The following is a description of a gene set: studied in species Homo sapiens The Lysophospholipid receptor (LPLR) group are members of the G protein-coupled receptor family of integral membrane proteins that are important for lipid signaling. In humans there are eight LPL receptors, each encoded by a separate gene (these genes also sometimes referred to as "Edg" or endothelial differentiation gene). The ligands for LPLRs are the lysophospholipid extracellular signaling molecules, lysophosphatidic acid (LPA) and sphingosine 1-phosphate (S1P). The primary effects are inhibition of adenylyl cyclase and release of calcium from the endoplasmic reticulum, as well as secondary effects of preventing apoptosis and increasing cell proliferation (Contos JJ et al, 2000; An S et al, 1998; Fukushima N and Chun J, 2001). Reactome Pathway: Lysosphingolipid and LPA receptors part of: Class A/1 (Rhodopsin-like receptors), and this is the list of marker genes: S1PR3, S1PR1, PLPPR2, LPAR3, LPAR5, PLPPR5 (NCBI Gene Id 163404), S1PR5, PLPPR1, LPAR2, S1PR2, LPAR1, PLPPR4, S1PR4, PLPPR3